The following is a description of a gene set: The chemical reactions and pathways resulting in the formation of pyrimidine nucleobases, 1,3-diazine, organic nitrogenous bases. species: Mus musculus Mouse Gene Set: GOBP_PYRIMIDINE_NUCLEOBASE_BIOSYNTHETIC_PROCESS, and this is the list of marker genes: Cps1, Dhodh, Mtor, Ctps2, Ctps1, Cad, Umps, Cmpk1